The following is a description of a gene set: Any of the spindle microtubules that come from each pole and overlap at the spindle midzone. This interdigitating structure consisting of antiparallel microtubules is responsible for pushing the poles of the spindle apart. studied in species Mus musculus Mouse Gene Set: GOCC_POLAR_MICROTUBULE, and this is the list of marker genes: Cul3, Klhl21, Tubg1, Tubgcp3, Klhl22